Given this list of marker genes Gpi1, Ppp2ca, Pfkfb1, Prkaca, Slc4a1, here is a description of the gene set: Mouse Gene Set: GOBP_REGULATION_OF_GLYCOLYTIC_PROCESS_THROUGH_FRUCTOSE_6_PHOSPHATE Any process that modulates the frequency, rate or extent of glycolytic process through fructose-6-phosphate. studied in species Mus musculus